Given this list of marker genes Pinx1, Stn1, Smg6, Dcp2, Gnl3l, Hnrnpu, Terf1, Pot1a, Ercc4, Trp53, Ctc1, Rad50, Ercc1, Hnrnpc, Tnks2, Mcrs1, Nat10, Atm, Terf2ip, Terf2, Tent4b, Nbn, Ten1, Pif1, Pml, Xrcc1, Tinf2, Src, Xrcc4, Rtel1, Parp1, Exosc10, Tnks, Acd, Slx4 (NCBI Gene Id 52864), Pot1b, here is a description of the gene set: Any process that stops, prevents, or reduces the frequency, rate or extent of a process that affects and monitors the activity of telomeric proteins and the length of telomeric DNA. studied in species Mus musculus Mouse Gene Set: GOBP_NEGATIVE_REGULATION_OF_TELOMERE_MAINTENANCE